Given this list of marker genes ERMN, GPRASP1, EFCAB13, WNT7A, RALGPS2, NKAPP1, TOP1MT, TPH1 (tryptophan hydroxylase 1), ARHGAP32, DIP2B, UPP1, UBE3D, ELK4, VWA8, IPCEF1, PNRC1, NDRG2, CNKSR2, CHTOP, CCDC57, GGT7, DGKD, RPL5, ZNF331, ABCC2, SF1, ERCC6L2, ACAD11, CASP10, MSX2P1, LINS1 (NCBI Gene Id 55180), CHMP7, TGFBR2, CPSF6, EPHA1, ETS1, ZNF638, LTBP3 (latent transforming growth factor beta binding protein 3), ACVR1C, WDPCP, FLACC1, SIN3B, TPM2, ZNF229, DCAF16, DDX60, ZNF107, FAM117B, ADGRL1, CCNH, TMEM131L, SLC4A5, MAGEE1, NR3C2, PEX3, WDR27, SNRPA1, PBX2 (NCBI Gene Id 5089), SARAF, BACH2, APBB1, SLC38A6, PDK1, PHKA2, NCK2, SMARCA2, ING5, PIAS1, SMARCA1, CENPV, SPPL2B (NCBI Gene Id 63937), IFIT1, TRMT11, AFG2A, MAML2, CHD2, PLPP6, ALMS1, TIMD4, ATP1A1, GCDH, PFN2, ZNF540, ZFYVE9, SON, RGS10, ZNF682, SGTB, EDAR, SNRPN, MBNL1, TOM1L2, SLC25A37, ZNF573, ZNF626, NOG, ZNF157, RPS3A, TCEA3, EPHX2, GAL3ST4, ICE2, FOXO1, CFAP70 (NCBI Gene Id 118491), DDX31, LINC00921, PLAC8, ADAMTS17, SIAH3, FAM86DP, NFKBIZ, LETMD1, EXPH5, ACACB, TRAPPC14, RIMKLB (NCBI Gene Id 57494), SNORD4A, BCL2, RNF216, STAT4, RASA2, ZMYND8, PCED1A, TTN, TPCN1, DHX58, KPNA5, BEX5, PHC3, ATP11C, USP44 (NCBI Gene Id 84101), CCDC88A, AK5, LAIR1, HNRNPDL, WWC2, NOL4L, PLXDC1, RASGRP2, DNAJB13, RPL9, POLI, PITPNM2, IFT122, SLC8B1, MCMDC2, OLFM2, ENGASE, NRF1, NUP160, CD69, ZNF204P, FHIP1B, CHML, SPG11, RPS20, SUPT3H, PTK2, SNORA27, LDLRAP1, TMEM220, MINDY1, ITPKB, FBP1, TNFRSF10D, RECK, CAMK1D, PLCL1, APBA2, METTL22, LINC01089, SETMAR, ZDHHC17, MPP7, RPL35A, FHIT (fragile histidine triad diadenosine triphosphatase), CEP95, UBR3, KLF3-AS1, PXYLP1, C1orf162 (chromosome 1 open reading frame 162), ZNF337, CCDC180, CFAP44, LEMD2, HSF2, MAGOHB, RPGR, C12orf42, ZCWPW1, YJU2B, SCML1, SBDS, TMCO6, PECAM1, XKRX, MAN1C1, BRD10, DHRS3, here is a description of the gene set: from publication Min L, Isa SA, Fam WN, Sze SK, Beretta O, Mortellaro A, Ruedl C (PMID 22250091) species: Homo sapiens Genes up-regulated in bone marrow-derived dendritic cells: unstimulated versus CSF2. Human Gene Set: GSE32986_UNSTIM_VS_GMCSF_STIM_DC_UP A simultaneous engagement of different pathogen recognition receptors provides a tailor made adaptive immunity for an efficient defence against distinct pathogens. For example, cross talk of TLR and c-type lectin signalling effectively shapes distinct gene expression patterns by integrating the signals at the level of NF-κB. Here, we extend this principle to a strong synergism between the Dectin-1 agonist, curdlan, and an inflammatory growth factor, GM-CSF. Both together act in synergy in inducing a strong inflammatory signature which converts immature DCs to potent effector DCs. A variety of cytokines (IL-1β, IL-6, TNF-α, IL-2 and IL-12p70), costimulatory molecules (CD80, CD86, CD40 and CD70), chemokines (CxCl1, CxCl2, CxCl3, CCl12, CCl17) as well as receptors and molecules involved in fugal recognition and immunity such as Mincle, Dectin-1, Dectin-2 and Pentraxin 3 are strongly up-regulated in DC treated simultaneously with curdlan and GM-CSF. The synergistic effect of both stimuli resulted in strong IKBα phosphorylation, in its rapid degradation and in enhanced nuclear translocation of all NF-κB subunits. We further identified MAPK ERK, as one possible integration site of both signals, since its phosphorylation was clearly augmented when curdlan was co-applied with GM-CSF. Our data demonstrate that the immunomodulatory activity of curdlan requires an additional signal provided by GM-CSF to successfully initiate a robust β-glucan specific cytokine and chemokine response. The integration of both signals clearly prime and tailor a more effective innate and adaptive response against invading microbes and fungi.